Given this list of marker genes INS (NCBI Gene Id 3630), IRS2, GRB10, INSR, IRS1, here is a description of the gene set: species: Homo sapiens IRS is one of the mediators of insulin signalling events. It is activated by phosphorylation and triggers a cascade of events involving PI3K, SOS, RAF and the MAP kinases. The proteins mentioned under IRS are examples of IRS family members acting as indicated. More family members are to be confirmed and added in the future. Using receptor mutagenesis studies it is known that IRS1 via its PTB domain binds to the insulin receptor at the juxtamembrane region at tyrosine 972. The interaction is further stabilized by the PH domain of IRS1 which interacts with the phospholipids of the plasma membrane. This allows the receptor to phosphorylate IRS1 on up to 13 of its tyrosine residues. Once phosphorylated the IRS1 falls away from the receptor. Now in a tyrosine phosphorylated and hence activated state other proteins can interact with the IRS proteins. part of: Insulin receptor signalling cascade Reactome Pathway: IRS activation